The following is a description of a gene set: The process in which ions are transported across the plasma membrane of an atrial cardiac muscle cell such that the membrane potential changes in the repolarizing direction, toward the steady state potential. For example, the repolarization during an action potential is from a positive membrane potential towards a negative resting potential. Mouse Gene Set: GOBP_ATRIAL_CARDIAC_MUSCLE_CELL_MEMBRANE_REPOLARIZATION studied in species Mus musculus, and this is the list of marker genes: Kcnq1, Kcnn2, Flna, Kcne5 (potassium voltage-gated channel subfamily E regulatory subunit 5), Scn5a, Kcna5, Nppa, Kcnj5, Cacna1d